Given this list of marker genes AIG1, B4GALT5, NINJ1, RABGGTA, DBNDD1, SNX20, C18orf32, BYSL, MCEMP1, COPE, COQ7, LACC1, NRP2, CUL2, PAG1, ABCA1, MAGT1, DYNC1LI1, COX17, AGRN, S100A11, MKKS, GKAP1, SLC31A2, GTF2A1, FCGR3A, CINP, IFITM3, POFUT2, TGM2, TMEM119, SPRY2, SVIL, TLR5, NFE2L2, PLA2G4A, PPA1, KMO, ITGB2, CIAPIN1, PLEKHG1, AGPAT4 (NCBI Gene Id 56895), COMMD10, RAF1, HLA-DRB1, CDV3, TRAF2, PCID2, RGL1, MRPL52, UQCRQ, SENP5, TTC39B, RAB10, DDHD1, DLAT, IL13RA1, MAFB, MTURN, CLN5, PYGL, MCFD2, C1R, SLC2A6, ARMC1, MAFG, UBXN8, SLC16A1, LENG9, DUS4L, ABHD17C, CLDND1, PTPRU, PFN1, ODC1, PELO, SQLE, USO1, TMEM248, VPS37A, C9orf72, HSD17B12, FBXO30, PSMB8, TTC39C, RAB7A, PRELID2, MMP13, LAMP1, CCND3, CD74, PSMB9, IFNAR1 (NCBI Gene Id 3454), PARP3, HOMER1, CISH, WBP1L, TSPO, SMIM3, MMP19, GRINA, TTPAL (alpha tocopherol transfer protein like), CDC37L1 (cell division cycle 37 like 1, HSP90 cochaperone), H3C14, CREB5, IL18BP, COX8A, DNAJC21 (NCBI Gene Id 134218), IRAK2, NR3C1, GCNT2, TM7SF2, STUB1, VRK3 (VRK serine/threonine kinase 3), FABP5, MPHOSPH10, IFNGR2, TRAPPC6A, DNAJC3, SC5D, NOP10, PKM, UBE2F (NCBI Gene Id 23665), METAP1 (methionyl aminopeptidase 1), ZCCHC14, DNAJB1, PPP1R14B, ECHS1, HLA-DQA1, JUN, LTV1 (LTV1 ribosome biogenesis factor), MTHFR, SPIC, COMTD1, BIRC3, TANC2, ZNF292, GCLM, TRAPPC14, NEU1, ATG4A, LRRC8C, FARP2, MTM1, HIPK2, PLSCR1, AKAP7, CRELD2, IFT57, TMEM243, ABCF2, P2RX4, NFKBIB, FLOT1, KLHDC9, GFPT1, CEBPD, CEPT1, CDC42EP2, MLLT6, EGLN3, RNGTT, NPEPPS, NRAP, AARS1, SLC11A1, HLA-DOA, C8orf76, GK, ARF1, HCCS, CMKLR1, GPX4, HPSE, FCGR2A, PECAM1, TRAF5, CYBB, NAB2, CYBA, TPCN2, RAB1B, TRPS1, SAMSN1, TPST2, TIMM8B, ETHE1, RMDN3, RAPGEF2, PLBD1, RAP1GDS1, STK40, MANF, AACS, SNAPC1, ATOX1, SEMA4A, PSTPIP2, HOOK2, TFEC, here is a description of the gene set: The interferon-producing plasmacytoid dendritic cells (PDC) share common progenitors with antigen-presenting classical dendritic cells (cDC), yet they possess distinct morphology and molecular features resembling those of lymphocytes. It is unclear whether the unique cell fate of PDC is actively maintained in the steady state. We report that the deletion of transcription factor E2-2 from mature peripheral PDC caused their spontaneous differentiation into cells with cDC properties. This included the loss of PDC markers, increase in MHC class II expression and T cell priming capacity, acquisition of dendritic morphology and induction of cDC signature genes. Genome-wide chromatin immunoprecipitation revealed direct binding of E2-2 to key PDC-specific and lymphoid genes, as well as to certain genes enriched in cDC. Thus, E2-2 actively maintains the cell fate of mature PDC and opposes the “default” cDC fate, in part through direct regulation of lineage-specific gene expression programs. species: Homo sapiens from publication Ghosh HS, Cisse B, Bunin A, Lewis KL, Reizis B (PMID 21145760) Human Gene Set: GSE24726_WT_VS_E2_2_KO_PDC_DAY4_POST_DELETION_UP Genes up-regulated in plasmacytoid dendritic cells (4 days after knockout): wildtype versus TCF4 knockout.